Given this list of marker genes CXCL11, WDR1, CDV3, SERPINE2, MX1, FGFBP1, CSF3 (colony stimulating factor 3), CA12, SFRP1, RAB5A, PTPRK, CALD1, PTGS2, CDH11, YKT6, ARHGAP25, PRSS2, IFI27, WIPF1, DHX9, VNN1, CYP51A1, HRH1, TNC, CLIC4, EMP3, ITGB6, NUP160, LPXN, CHP1, SPOCK1, GREM1, IGF2, MMP3, FN1, IFI16, NF2, PRNP, PCDH7, SCG5, SRGN, TGFBR1, MAN1A1, S100A9, IFI6, APOBEC3G (NCBI Gene Id 80065), RIGI, OAS2, RAB6A, ARL4C, PTPN11, PLK2, SLC4A7, SNHG14, MAP1B, CRYBB2, SORL1, FOXA2, SNRPN, CDK17, FLI1, CPS1, FEZ1, PALLD (NCBI Gene Id 51653), NEFL, FST, MCL1, DUSP4, KCNMA1, NUP188, NSG1, PID1, HMGCS1, THBS1, SSR3, DCBLD2, PRSS3P2, G0S2, TP63, COPA, COL5A1, OAS1, VSNL1, GPX3, CLDN1, STX10, IL13RA1, SH2D2A, STX16, COL5A2, CALB1 (calbindin 1), TGFBR2, GNG11, RPS4Y1, JAG1, XYLT1 (NCBI Gene Id 64131), SRSF6, G3BP2, S100A8, AOX1, TGFA, IL13RA2, NEAT1, TWF1, CUX2, IFITM1, CCND2, LTBP1, PLTP, NNMT, DPYSL3, DDX3X, CFH, B4GALT1, ARMCX2, NUPR1, CALU, EOGT, PRSS3, ELAVL2, GABPB1, ROBO3, ARHGDIB, PDPN, CALML3, PTBP3, here is a description of the gene set: The persistent activation of signal transducer and activator of transcription 3 (Stat3) is a common feature of prostate cancer. However, little is known about the Stat3 targets that may mediate prostate tumorigenesis. The introduction of an activating mutant form of Stat3 (Stat3-C) into immortalized prostate epithelial cells resulted in tumorigenesis. Stat3-C-expressing cells had decreased E-cadherin levels, increased numbers of lamellipodia and stress fibers, and enhanced migratory capacities compared to vector control-expressing cells, with a concomitant increase in the expression of integrin beta6 and its ligand, fibronectin (FN). Exogenously added FN increased cellular migration, with a concomitant loss of E-cadherin expression. The blockade of integrin alphavbeta6 in Stat3-C-expressing cells inhibited migration, increased E-cadherin levels, and reduced colony formation in soft agar. These results demonstrate the sufficiency of constitutively activated Stat3 in mediating prostate tumorigenesis and identify novel Stat3 targets that are involved in promoting cell migration and transformation. Genes up-regulated in RWPE-1 cells (prostate cancer) upon expression of constitutively active form of STAT3. species: Homo sapiens from publication Azare J, Leslie K, Al-Ahmadie H, Gerald W, Weinreb PH, Violette SM, Bromberg J (PMID 17438134) Human Gene Set: AZARE_NEOPLASTIC_TRANSFORMATION_BY_STAT3_UP